The following is a description of a gene set: studied in species Homo sapiens from publication Usher MG, Duan SZ, Ivaschenko CY, Frieler RA, Berger S, Schütz G, Lumeng CN, Mortensen RM (PMID 20697155) Inappropriate excess of the steroid hormone aldosterone, which is a mineralocorticoid receptor (MR) agonist, is associated with increased inflammation and risk of cardiovascular disease. MR antagonists are cardioprotective and antiinflammatory in vivo, and evidence suggests that they mediate these effects in part by aldosterone- independent mechanisms. We used affymetrix to characterize the effect of Mineralocorticoid Receptor deletion on macrophage transcriptional profile, and identify its requirement in normal glucocorticoid signalling. Human Gene Set: GSE23308_WT_VS_MINERALCORTICOID_REC_KO_MACROPHAGE_CORTICOSTERONE_TREATED_UP Genes up-regulated in macrophages treated by corticosterone: wildtype versus NR3C2 knockout., and this is the list of marker genes: TIMM10B, GALNS, ATP6V1A, ZSCAN26, MBNL1, MBD6, LPIN1, IFT70A, DNMT3B, C15orf39, NDUFA11, HAGH, GCDH, FBXO25, APBB2, SNAP47, TRPV2, CD99L2, ABHD8, EID1, GANAB, AAK1, RASSF8, JMJD1C (jumonji domain containing 1C), GNG2, ANKMY2, FAM120B, NDUFA3, IFT140, PLIN3, TP53INP1, KLF13, ABL1, DHRS7B, TMEM268, SCAND1, FCHSD1, IL7R, RELL1, NTPCR, CIB2, GTF3A, P2RY6, ZNF24, NUDT3, CENPO (centromere protein O), NDUFV2, MCM7, LRRC40, DYNLT1, PGAP6, ARMC7, SLC25A39, RFC2, TTC5, TPGS1, STK17B, YIPF3, R3HDM1, SNX21, NUDT6, DMAC2L (NCBI Gene Id 27109), ZFP36L2, ZNF219, SIAE, SLC46A3, SBF2, PCYT1A, SLC19A2, PRKCI, ZNF566, DNAJC9, VPS11, MPG, CHD1L, GLO1, ACADM, RNF167, THAP7, ST6GAL1, RPRD1B, MEF2C, WDFY1, RETREG1, TOMM6, RMND5B, RECQL, GSDME, FANCF, ALG5, MRM2 (mitochondrial rRNA methyltransferase 2), ARHGAP12, MRPL23, PREPL, IRF2BP1, POU6F1, CRAMP1, DBNDD2, UNC119, RPA1, CD93, APOBEC1, BTBD2, TEX261, IGFBP4, RNPEPL1, OCEL1, AP1S2, ZFP90, ADCY9, HSPBP1, DECR1, ARHGEF7, CTSD, TIAM1, SLC25A11, EBAG9, GBA2, CHMP6 (NCBI Gene Id 79643), NAGK, COMT, MYG1, FUNDC1, MXI1, ERI3, LAT2, ETFDH, LAMP2, PTPA, CDADC1, FECH, LSM5, EMILIN1, DNAJC17, ITCH, ZNF362, TPTE, ARL8B, TCTN3, GRB2, SARAF, THBS1, IFT81, FBXO8, NCKIPSD, ORC5, ZNF282, PPM1D, ABHD17A, C7orf25, CTNS, SOX13, CNR2, BOLA1, LTO1, MIS18A, PURG, CERS2, CYTIP, CERK, GLMP, SEC14L1, SMAD7, TSG101, RNF138, DHRS1, TSPAN14, PRKAG1, MICAL1, CLTC, CD300C, METTL13, GTF2I, ETAA1, ATP5F1E, SRCAP, COQ8A, KIAA1143, CPSF3, DNAJC28, ZCCHC8, PHKA2, GPSM3, DCXR, ATP6V1D, ST6GALNAC4, ARMC10, RETREG2, IVNS1ABP, ZDHHC12, TMEM150B, CARM1, LACTB, PCMTD2, SPPL3, INPP1, ATMIN, ZNF395, NHSL3 (NHS like 3)